Given this list of marker genes Sec61b, Cyb5a, Vamp2, Ube2j2, Sgta, App, Aldh3a2, Sec61bl, Serp1, Stx5a, Sec61g, Hmox1, Vapa (NCBI Gene Id 30960), Emd, Prnp (prion protein), Stx1a, here is a description of the gene set: Insertion of tail-anchored proteins into the endoplasmic reticulum membrane Mouse Gene Set: REACTOME_INSERTION_OF_TAIL_ANCHORED_PROTEINS_INTO_THE_ENDOPLASMIC_RETICULUM_MEMBRANE studied in species Mus musculus